Given this list of marker genes AOX3P, CDK6-AS1, LZTFL1, PLK4, THEMIS, TMSB15B (NCBI Gene Id 286527), UBASH3A, LIG4, LINC01222, GVINP1, PXYLP1, LINC01934, ZFP1, NEIL3, HKDC1, FBXO41, PHGDH, LTA, BEST3, CD40LG, CD96, LINC00954, ARHGAP19-SLIT1, KLRC4-KLRK1, UBIAD1 (UbiA prenyltransferase domain containing 1), LIN28B, LINC01749, SKA3, TSHR, LINC00539, here is a description of the gene set: from publication Cao J, O'Day DR, Pliner HA, Kingsley PD, Deng M, Daza RM, Zager MA, Aldinger KA, Blecher-Gonen R, Zhang F, Spielmann M, Palis J, Doherty D, Steemers FJ, Glass IA, Trapnell C, Shendure J (PMID 33184181) Marker genes curated from the annotated cluster as represented in the Descartes Human Gene Expression During Development database. studied in species Homo sapiens Human Gene Set: DESCARTES_FETAL_THYMUS_THYMOCYTES The gene expression program underlying the specification of human cell types is of fundamental interest. The study authors generated human cell atlases of gene expression and chromatin accessibility in fetal tissues. For gene expression, the study authors applied three-level combinatorial indexing to >110 samples representing 15 organs, ultimately profiling ~4 million single cells. The study authors leveraged the literature and other atlases to identify and annotate hundreds of cell types and subtypes, both within and across tissues. Our analyses focused on organ-specific specializations of broadly distributed cell types (such as blood, endothelial, and epithelial), sites of fetal erythropoiesis (which notably included the adrenal gland), and integration with mouse developmental atlases (such as conserved specification of blood cells). These data represent a rich resource for the exploration of in vivo human gene expression in diverse tissues and cell types.